Given this list of marker genes NLK, RSBN1, LDLR, GALNT1, CYCS, BMP2K, PHACTR4, CD69, LEPROT, PLXDC2, PBX1, ATP6V0A2, SESN3, MYB, DEPTOR, HTR1F, ERG, TESPA1, EIF2AK1, EREG, IMPA1, SLA, SLC39A8, CRHBP, TEC, HSP90AA1, CDK6, RIPOR3, SLC40A1, IL1RL1, PDZD8, ZNF711, SPTY2D1, SDCBP, HPGDS, MYCT1, PRKACB, ITGAE, MLLT3, ELF1, GNAI1, RHOH, TSEN54, CCND2, CELF2, PKIG (NCBI Gene Id 11142), GATA2, SERPINB1, MOB1B, ZEB2, MED12L, PSTPIP2 (NCBI Gene Id 9078), CTNNBL1 (catenin beta like 1), NFKBIZ, DGKE, SMIM27, STK4, TNIK, MT-RNR2 (NCBI Gene Id 4550), DDX21 (NCBI Gene Id 9188), ZFAS1, CKAP2, SNX5, ZMYND8, ZBTB20, ITPRID2, CD84, ZBTB16, NFIA, ARHGAP15, NOP58, JUN, RAPGEF2, SKIL, KIT, CAMLG, CPA3, CRACD, ELMO1, FOXO3, EWSR1, PHTF1, RNF130, YARS1, IKZF2, TSPYL2, LAPTM4A, ITGA4, ETS2, DTD1, PNN, SLC38A2, ABCA1, G3BP2, TAF1D, MAN2A2, MPP1, here is a description of the gene set: from publication Zheng S, Papalexi E, Butler A, Stephenson W, Satija R (PMID 29545397) studied in species Homo sapiens Human Gene Set: ZHENG_CORD_BLOOD_C4_PUTATIVE_EARLY_ERYTHROID_COMMITMENT